Given this list of marker genes TSC1, VHL, PELI1, DEPDC5, NLK, SEH1L, ATM, SAR1B, WDR24, CASTOR2, ITFG2, STK11, RNF152, SESN2, SESN1, SPAAR, ATXN3, PRKACB, PRKAA2, UBE3A, SAMTOR, ATXN3L, YWHAG, USP7, SEC13, WDR59 (NCBI Gene Id 80779), CASTOR1, NPRL3, TBC1D7, AKT1S1 (AKT1 substrate 1), NPRL2 (NCBI Gene Id 10641), DEPTOR, YWHAZ, NPC1, OTUD7B, SESN3, MIOS, MAPK3, TSC2, PRKACA, UBE2N, RNF167, TBK1, PRKAA1, SZT2, UBE2W, KICS2, SAR1A, UBE2D1, KPTN, CASTOR3P, here is a description of the gene set: Any process that stops, prevents or reduces the frequency, rate or extent of TORC1 signaling. Human Gene Set: GOBP_NEGATIVE_REGULATION_OF_TORC1_SIGNALING species: Homo sapiens